Given this list of marker genes Glb1l (galactosidase, beta 1-like), Cog2, Dkk1, Rsbn1, Lgalsl, Gxylt1, Tenm4, Tfrc, Bahd1, Cdyl2, Dmd, Zbtb21, Tmem145, Nfat5, E2f2, 2310033P09Rik, Col5a1, Rhobtb1, 6430548M08Rik (NCBI Gene Id 234797), Topbp1, Atp8a1, Uhrf2, Sh2d1a, Kctd21, Slbp, Cacnb2, Bicra, Pdzd4, Rgs18, Pex5, Tet1, Zfp36l1, Oxsr1, Fech, Bicd1, Sh3bp1, Spred1, Tom1l1, Gpc6 (NCBI Gene Id 77735), Ak4, Pcdh17, Khdrbs3, Snx4, Sgms1, Pcx, Ammecr1, Zscan18, Clcf1, Serpinb9c, Stk40, Map3k1, Sema6d, Homer1, Lin7c, Rhbdl3, Ces1g, Pik3c2a, Atl2, Cebpa, Gpr21, C2cd2, Flot1, Depdc5, B4galt6, Igsf11, Ucn2, B3gnt2, Slc1a2, Slc25a28, Ahcyl1, Psd4, Tmprss11f, Cfap418, Wdr41, Osbp2, Lats2, Dusp7, Glcci1 (NCBI Gene Id 76466), Crppa, Wdr5, Fam89a, Bach2, Xndc1, Tns1, Pdpr, Retreg1, Fzd3, Zfp799, Il34, Gfm2, Mfsd14a, Numb, Slc5a7, Dlx4, Abat, Tacc1, Wnk1, Clock (clock circadian regulator), Jazf1, Pou2f1, Sugt1, Nup153, Syde2, Hsph1, Ahsa2, Ovca2, Stx12, Krtap11-1, here is a description of the gene set: Mouse Gene Set: MIR_31_5P Genes predicted to be targets of miRBase v22 microRNA mmu_miR_31_5p in miRDB v6.0 with MirTarget v4 prediction scores > 80 (high confidence targets). from publication Chen Y, Wang X (PMID 31504780) species: Mus musculus